The following is a description of a gene set: Proteins that interact with PTTG1, based on protein array. Pituitary tumor transforming gene 1 (PTTG1), a transforming gene highly expressed in several cancers, is a mammalian securin protein regulating both G1/S and G2/M phases. Using protein array screening, we showed PTTG1 interacting with Aurora kinase A (Aurora-A), and confirmed the interaction using co-immunoprecipitation, His-tagged pull-down assays and intracellular immunofluorescence colocalization. PTTG1 transfection into HCT116 cells prevented Aurora-A T288 autophosphorylation, inhibited phosphorylation of the histone H3 Aurora-A substrate and resulted in abnormally condensed chromatin. PTTG1-null cell proliferation was more sensitive to Aurora-A knock down and to Aurora kinase Inhibitor III treatment. The results indicate that PTTG1 and Aurora-A interact to regulate cellular responses to anti-neoplastic drugs. PTTG1 knockdown is therefore a potential approach to improve the efficacy of tumor Aurora kinase inhibitors. from publication Tong Y, Ben-Shlomo A, Zhou C, Wawrowsky K, Melmed S (PMID 18663361) Human Gene Set: TONG_INTERACT_WITH_PTTG1 studied in species Homo sapiens, and this is the list of marker genes: CNP, NHP2, AEBP2, UTP4, RNPC3, ATAT1, C7orf50, FGF13, ARL6IP4, CCDC149, ERI1, ATP5PO, EIF2S2, PYM1, PDE6H, GSTM3, GABARAPL1, RPF2, TYMSOS, CDC42SE1, DDX54, APOBEC3F, PUS7L, PHF11, TMEM237, LLPH, IER3, RSL24D1, PLK3, RPS15, PPFIBP2, RPL41, PTRH1, HMGN2, TEAD4, DDX47, KIAA1191, RPL31, TBPL1, AURKA, ZNF740, AIFM3, RPL26L1, CTNND1, WDR5, RPS10, ARPC1B, NOB1, MTG1, ADAP2, C19orf53, RPS26, RPL30, ZMAT4, TRIM41, ABT1, PIMREG